The following is a description of a gene set: from publication Kohn LA, Hao QL, Sasidharan R, Parekh C, Ge S, Zhu Y, Mikkola HK, Crooks GM (PMID 22941246) Genes down-regulated in the bone marrow CD34+ cells: CD38- versus MME- SELL+. Studies of adult human hematopoiesis have until now relied on the expression of CD10 to define lymphoid commitment. We report a novel lymphoid-primed population in human bone marrow that is generated from hematopoietic stem cells (HSC) prior to the onset of CD10 expression and B cell commitment, and is identified by high levels of the homing molecule L-selectin (CD62L). CD10-CD62Lhi progenitors have full lymphoid (B/T/NK) potential, and show reduced myeloid and absent erythroid potential. Genome-wide gene expression analysis demonstrates that the CD10-CD62Lhi population represents an intermediate stage of differentiation between CD34+CD38- HSC and CD34+lin-CD10+ progenitors marked by down-regulation of TAL1 and MPL, upregulation of E2A, CD3E and IL2RG expression, and absent B cell commitment or RAG1/2 expression. Immature CD34+CD1a- thymocytes are also CD62Lhi and L-selectin ligands are expressed at the cortico-medullary junction, suggesting a possible role for L-selectin in human thymic homing. These studies identify the earliest stage of lymphoid priming in human bone marrow. studied in species Homo sapiens Human Gene Set: GSE35685_CD34POS_CD38NEG_VS_CD34POS_CD10NEG_CD62LPOS_BONE_MARROW_DN, and this is the list of marker genes: KCNAB3, CELSR1, TGFBI (NCBI Gene Id 982), C11orf16, WNT10B, SPHK2, PHLDB2, EPHA8, NDRG1, CDCP1, RHOG, CLPX, MPP7, ADRA2C, EFNA4, IMMT, FCGR2B, RWDD4, TPSB2, CHCHD10, MYT1, CLCN1, JARID2, DHH, BRS3, NABP1, SF3A1, RABGGTA, NEUROG1, ELK3, AP2A2, PTPRE (protein tyrosine phosphatase receptor type E), KCNC1, FERMT2, OSBPL11, KIF3A, LRP10, DNM2, PSME2, VWA7, AP2A1, TNFSF11, IL13RA1, NPPC, STAT5A, ATG4B, KLHDC4, MRPL41 (NCBI Gene Id 64975), PTGDR2, WDR20, NSF, SNX6, AP2M1, PNPO, ALDOB, CLEC16A, KRT13 (NCBI Gene Id 3860), SEC24C, RAB11FIP5, NSMCE1, GAPDH, NKIRAS1, LPP, FGL2, BEX1, TIMP1, FCGR1A, GAS1, MGAT1, FBXO6, MYL11, TFF1, C9orf72, PARD6A, ENTPD7, ASL, MLX, HMOX1, RAB4B, TRIM46, IL18BP, PACSIN1, MRPL49, MTMR10, FABP5, STAT5B, MKNK1, TSPO, ABCF3, POP4, NTF3, ASAP1, ITPR1, DSG2, ZNF799, IL5, GRAMD2B, COPS7B, MATN1, LIFR, SOAT2, NECTIN2, SNRPA, SLC25A48, ARFIP2, IGFBP6, AATK (apoptosis associated tyrosine kinase), CYP4A11, SNX1, HOXC5, CTSH, IFNAR1, LTB4R, STAT3, SLC31A1, PIP5K1B, ITSN1, MAP3K2, BMP2K, TNFRSF11A, URM1, EDNRB, HBE1, TMEM214, DNAJC5, SH3GL1, SEC61A1, RHOB, PTGER1, MUC1, SLC35B1, ATP6V0C, SDC4, RESP18, ALDH1A1, MAP1S, KCNJ6, TLR6, HSD3B1 (hydroxy-delta-5-steroid dehydrogenase, 3 beta- and steroid delta-isomerase 1), GATA1, NRTN, CAMK2B, ALKBH5, ADA, NMU, CSNK1D, PSMB9, MANF, NKX2-6, MOV10, LY6E, RNPEP, KRT81, CD22, TMT1A, FH, RAB8B, JAK3, GRINA, FBXL15, DALRD3, APBA3, CNN3, AP1B1, TCAP (NCBI Gene Id 8557), BAK1, ARNT, ESRRA, TNFAIP8, COX4I1, TMEFF2, RAI1, CASQ2, F3, SOAT1, HTT (NCBI Gene Id 3064), BRD3, NMBR, SLC6A2, IFITM3, ENPP1, WDR46, CFB, ITPKB (NCBI Gene Id 3707), EPHB2, PRDM5, CTSC, RREB1, CER1, STAC, SSBP4, GON4L, DYNC1I1, KRT12, RAB3IL1, BAG6, ROR1, PTCD2, TM2D2, MXD1 (MAX dimerization protein 1)